The following is a description of a gene set: species: Homo sapiens Reactome Pathway: Sorafenib-resistant PDGFR mutants part of: Drug resistance of PDGFR mutants Sorafenib is a type II tyrosine kinase inhibitor that is approved for use in hepatocellular and renal cell carcinoma, and that is often used as a second-line treatment for imatinib-resistant tumors. Despite its initial efficacy, resistance to sorafenib often develops., and this is the list of marker genes: PDGFRA (NCBI Gene Id 5156)